Given this list of marker genes Gab2, Nr4a3, Rabgef1, Tslp, Scn11a, Crlf2, Adora2b, Cnr2, Gpr15lg, Mrgprb1, Gata1, Adora3, Ywhaz, Timd6, Ptpre, Fcgr2b, D6Wsu163e, Syk, Enpp3, Cftr, Fes, Cbl, Cd300lf, Kit, Lat2, Timd5, Rac2, Rasgrp1, Crhr1, Snap23, Foxf1, Grp, Il4ra, Dppa1, Vamp8, Unc13d, Stxbp1, Nppc, Snx4, Sphk2, Ndrg1, Fgr, Btk, Fcer1g, Fcer1a, Mrgprx2, Bcl10, Milr1, Hmox1 (heme oxygenase 1), Tlr4, Ms4a2, Nppa, Stxbp2, Pdpk1, Ptpn6, Plscr2, Cd300lb, Nectin2, Plscr1, Fcgr3, Lat, Pld2, Lcp2, Cd84, Lilrb4b (NCBI Gene Id 14727), Ptgdr, Fer, Lyn, Chga, Il13ra2, Havcr1, Cd300a, Il13, Cd48, Cnr1, Cplx2, Il4, Pla2g3, Fyb1, Cd226, Clnk, Ptgds, Ighe, Tac4, Rhoh, Rab44, Slc18a2, Timd2, Gata2, Lilrb4a, here is a description of the gene set: studied in species Mus musculus The change in morphology and behavior of a mast cell resulting from exposure to a cytokine, chemokine, soluble factor, or to (at least in mammals) an antigen which the mast cell has specifically bound via IgE bound to Fc-epsilonRI receptors. Mouse Gene Set: GOBP_MAST_CELL_ACTIVATION